Given this list of marker genes ZNF280D, ZFHX2, PKP4, NAA50, SKA2, DACT3-AS1, LINC01852, ALOXE3, LARP4, DNAJC10, ZBTB9, FOXP2, SNORA17A, GGA1, LRRC27, CNPPD1, TMEM106C, STX18-AS1, PPM1H, SMG7, PRDM1, MCFD2, IGSF8, GAS2L3, HMGXB4 (HMG-box containing 4), CORO7, NBEAL1, ATP2B1, FZD4, ARHGAP19, RELL2, SNRPA, ALKBH4, PSD, TRMO, MIR4757 (microRNA 4757), ZNF707, PSMG3-AS1, HSP90B1, RABGAP1L, KIF26A-DT, CHP1, LINC03060, LSM2, DNAJB4, ADD3, SNHG17, DRAM1, ENSG00000273828, IWS1, RNU6ATAC, LINC01465, LINC02851, RANBP3-DT, ZFAND2A, MAZ, RNF216, SWSAP1, ZNF131, DEPDC1B, PMS2, ANLN, POP1, CCDC32, POLR2E (NCBI Gene Id 5434), MRPL45P2, USP35, KCTD2, DDX55, KDM1A, MPDU1-AS1, SYT8, PCF11, CFL1, MAPT, ATP5F1C, RPS27L, UBE3A, GTF3C5, UPP1, GAPDHP25, OVCA2 (OVCA2 serine hydrolase domain containing), CLDN12, STX8, YARS2, PIBF1, IPO4, ZNF8-ERVK3-1, NBPF1 (NBPF member 1), LRRC51, CARS2, TMEM106B, ENSG00000232876, FANCC, CENPJ, NUDCD3 (NCBI Gene Id 23386), NUBPL-DT, CDK13, RNU5A-1, BBS4, RIDA, FRYL, BSCL2, HTT-AS, FGFR1OP2, FOXM1, C1QL4, SRP14, CSNK1D, ARL2BP, METTL1, GABARAP, SLC39A9 (NCBI Gene Id 55334), MIGA2, XPC, PCID2, FASTK, KCTD21-AS1 (KCTD21 antisense RNA 1), TMEM232, YWHAZ, EIPR1, ANKRD54, BBIP1, TRMT13, MAPK10, GTF2H5, ZNF740, PRPSAP1, TSSK6, MICAL3, TLCD1, ERH, RPS11, TAS1R1, RABGEF1, RPL34, PMS2P3, ATXN2, SETD1A, OS9 (NCBI Gene Id 10956), FAM118A, SETD5, TRIM29, TMED2, POLR1F (RNA polymerase I subunit F), EIF2S1, CTNNBL1, EGR1, TMEM243, VPS39-DT, DCAF13, TMEM128, HILPDA-AS1, UBE2I, PPP1R15B-AS1, PCBP2, ZNFX1, PHTF2, PARP3, PEF1-AS1, LINC00649, SERINC3, RNU6-2, KDM2B, MAPK6-DT, ZNF622, SNORD95, ZZEF1, NME6, ERCC5, SCARB2, H1-12P, HERC1, CCDC163, MRPL58, DLL4, ZFAS1, CENPQ, LINC02363, DDX11, ATP1A1-AS1, SPRTN, SNX13, DACT3, TRIM56, SNORD42B (NCBI Gene Id 26808), TENT4A, CENPO, PPP1R13L, ZNF451-AS1, NIF3L1, DYNC2I1, LRRC40, PTCD1, PDK4, THAP5, ZNF691, NCAPD2 (non-SMC condensin I complex subunit D2), H2BC8, GDAP1, DDX11-AS1, CPNE1, C3orf52, CDCA3, TRIM32, ARIH1, MRNIP, TBX6 (NCBI Gene Id 6911), ETFA (NCBI Gene Id 2108), CTNS, CTDSPL2, TRIM41, ZNF552, MMUT, PAN2, DPP8, CYP51A1-AS1, GORASP2, AMPD2, SF3B1, NFX1, UTP18, DHPS, INTS13, RABL6, SERP1, MIRLET7IHG, TPT1-AS1 (NCBI Gene Id 100190939, TPT1 antisense RNA 1), CHRAC1, TPT1 (tumor protein, translationally-controlled 1), NUSAP1, CDH24, ORC2, TPST1, ZNF524, SCP2, NDC1, TEDC2, PPP6C (NCBI Gene Id 96749), YBX3, WDR12, CACNA2D4, CACUL1, EIF3G, IER2, HNRNPAB, MINDY2, SLC27A5, STN1, ZFPL1, COQ8A, FBXO8, NRGN-AS1, MAP3K11, SUPT3H, RMDN1, TRIM7, HSPA8, METTL4, ZMYND8, ZNF8, NOL9, ATG16L1 (autophagy related 16 like 1), ENSG00000233461, FNIP1, ARMH4, MEGF8, CORO7-PAM16, SNORD12C, NOL3, ITFG2, UBAP2L, CD109, CAV1, POLR2K, RNU6-8, PRKAB2, SPINT1-AS1, EEF2K, CC2D2B, HNRNPA2B1, MIR4515, PIWIL4, ALDH6A1, RBL1, PPT1, CLNS1A, HOXA7, MYCBPAP, SLC12A9-AS1, MIR5087, HECTD4, CAPZA2, NTMT1, LYRM7, TRIM25, DNAJC14, HTRA2, RSRC2, POLK, ZNF839, RNY3, RSF1, ULK3, MEMO1, TOMM40, CARD19, MAEA, LACTB2, CCDC6 (coiled-coil domain containing 6), CNNM2, MRPL4, NLGN1, RPL8, SOCS4, YTHDC2, LRRC1, CLASP2, SHOC2, SUPT4H1, PTPA, LIN52, PPP2R5E, BLOC1S4, SETD9, RAPGEF6, CBX3, RNU4-1, STYXL1, PFDN2, AAGAB, RNF34, SLC35D3 (solute carrier family 35 member D3), RAB6A, TMCC3 (transmembrane and coiled-coil domain family 3), FIZ1, INO80E, EMC3-AS1, UQCR10, SNORD24, SF3B3, MSRB2, PPP1R2, RAD51, SNHG15, MRPS18B, ENAH, WDR81 (NCBI Gene Id 780925), GGPS1, ERC1, SLC17A5, SNORD48, ARL5A, RPL37, STAG3L5P-PVRIG2P-PILRB, CMTR1, LANCL2, BDH1, TRIM23, WEE2-AS1, UBP1 (upstream binding protein 1), WASHC5 (NCBI Gene Id 9897), GAPDH-DT, C2orf49, ELF1, RNF14, CBFB, ALG1, GABPB1-AS1, SH3TC2-DT, HTT, RPS2, CD27-AS1, ARMC10, KPNA3, YIPF3, SLC25A3, RNF181, MMACHC, TUFT1, UNC5B-AS1, CYP51A1, TMEM184A, LINC01730, LINC02453, RANBP3, KBTBD4, KHSRP, DRAIC, NUBPL, QPCTL, ZC3H12D, RFX3-DT, ENSG00000272195, ANKHD1-EIF4EBP3, TMEM9B-AS1 (NCBI Gene Id 493900), LZTR1, EMC4, CSNK2B, CCNI2, ALKBH2, GID8, NOP2, NIT1, MCCC1, CISTR, HMGCS1, LAMC2, AKT2, TMEM87A, NEK8, ERCC2, GATM, SNORD1C, MARK3, SLC38A1, PC, NCAPG2, SOCS7, ARF1, PPIL3, BDP1, LTBP4, CUX1, PTGES3, BRIX1, SCAND2P, MAP3K1, RPF2, CNBP, C6orf89, SPINK4, SH3TC2, KATNBL1, PHOSPHO1, NDUFC2-KCTD14, MYH9-DT, SRP54, MIOS-DT, ATP8B4, POLR3B, ABCF1, LAMA3, TGS1, IL23A (interleukin 23 subunit alpha), CFLAR-AS1, KIFC2, GMCL1, OIP5, MRPL33, DDIT4, TGDS, LIMA1, SERGEF, GTF2IRD1P1 (NCBI Gene Id 731516), GGCX, ANXA4, PHAX, USP42, DYNLL1, UVRAG, ZFAND2A-DT, KLF7, TMEM248, DOLK, UVSSA, ABCB10, PKMYT1, CERS6, COX20P2, NUDT21, SUV39H2, CFAP298, RAD51-AS1, BAZ2A, BIRC6, MTFR2, RPL39L, PSMB9, RNVU1-21, KRR1, PPT2, EXD1, SDCBP, GDPGP1, ALDH4A1, GSS, RERE-AS1, ZNF74, INSIG1, SECISBP2L, APRT, NSMCE2, MYO7A, MCM7, TMEM39A, TDRD3, LETM1, MIR584, ZNF473, SNHG12, RAP1GDS1, ZCWPW1, PSMA3-AS1, RPS15A, ACTR5, C1orf198, PDK1, NDUFAF4P1, COX7C, SYNJ1, SDHAF1, RBM33, CSAD, GTPBP2, RDH11, SLC4A1AP, XKR9, SELENOI, NDUFS3 (NCBI Gene Id 4722), EPB41L5, NR2C1, PLEKHH1, KCTD21 (NCBI Gene Id 283219), ANKS1A, PSMG3, IQCH, POLR3D, MIR4466, USP54, SCAMP2, MVB12A, VAV2, FHIP1B, ZNF398, ARHGEF26-AS1, RMRP, GART, CENPL, EFCAB15P, EXOSC9, CCDC77, ZZZ3, MSH5, IMMT, SEC22C, SEC31A, ARHGEF26, AGPAT5, AIMP2, GAPDH, PCBP1-AS1, NIPA1, YEATS4, CLHC1, IVD, EIF3L, ACTR3C, FSIP1, NOL8, TOMM22-DT, ZNF212, IFT172, LINC02086, FBXW7, TSEN2, NDC80 (NDC80 kinetochore complex component), ELP2, RTCA, UBE2L3, CEP120, FZD4-DT, PLEKHB2, EEF1AKMT3, NMRAL1, ARID4A, MIR7845, PUF60, TIMM21, CDON, FAM47E, DRG2, ATAD5, DDX49, CTDSPL2-DT, GPRASP3, CETN3, ZNF8-DT, DEPDC4, AJUBA, SEC24A, MRPS27, EML6, SPECC1, MTF2, STAG3L5P, GOT1-DT, HDLBP, PPP6R1, TFCP2, KNTC1, WASF2, CHMP7, INKA2, MUS81, NUDT19-DT, TYMP, ING1, TMED10, HCG18, MPV17L2, BMPR1A, AREG, FAM222B, TMEM161B-DT, ANKHD1-DT, SUPT7L, CRYBB2P1, TRIM27, VRK3, TXNDC11, UBR4, H2AC6, AMN1, UBE2Z, NFYC, MRFAP1L2, TBK1, LINC01182, KCTD13-DT, MYH9, TPK1, GPANK1, ATG4C, SPAG7, GTF3C2-AS2, ELOVL1, FBXO15, XPOT (exportin for tRNA), ATP5IF1, SNRPB2, HINT1, VWDE, SNORA84, ACP2, SLC39A6, TTC13, NOLC1, EED, BUD31, MPV17, RAD9A, TRA2A, ZC3HC1 (zinc finger C3HC-type containing 1), PRPF38B, TTC41P, MIRLET7BHG, IER3, SNHG32, TMEM143, ITPR1-DT, ZNF598, BZW2 (NCBI Gene Id 28969), PAWR, ZNF691-DT, GTF3C2, THTPA, TAF1B, EIF3H, SMG7-AS1, PEX1, TYW3 (tRNA-yW synthesizing protein 3 homolog), ANGPTL4, FEM1B, PEX26, PPP1R14B-AS1, CD320, SNRPD2, ATP6V1A, CCDC137, ARV1, HENMT1, WDR18, KHDRBS1, COG2, DNAJB12, CEP95, INO80B-WBP1, RACK1, TRIT1, B9D2, PPAN, ATP5PD, LMO7, TBC1D2, CUL4A, ZMAT5, CEP44, CCDC28A-AS1, SYNGAP1-AS1, PRSS3, DDX54, CYSTM1, DNASE2, NUP50-DT, PDAP1, SLC38A2-AS1, RPS9, NDUFA13, CAPN2, GPATCH11 (NCBI Gene Id 253635), ZNRF2P1, GOT1, RFX3, LSM11, MIR200C, APOL1, FAAP24, MAD2L1BP, ALG8, ASH2L, LARP1, POLG, YDJC, BRSK2, APH1A, RNF216P1, ZDHHC12-DT, ZBTB3, SPATA2, INO80B, SYNGR4, RPS6KA5, LRWD1, WDR27, CASD1, NUDT6, AFG1L (NCBI Gene Id 246269), PRRT1, CIAO2B, CES2, MAPK6, RITA1, DNAJC9-AS1, TUG1, TMEM39B, FDXR, CXXC1, RERE, ITFG2-AS1, AEN, GLUL (glutamate-ammonia ligase), ZSCAN2, MYO19, RPL31, CCNDBP1, PPP6R2, POM121, SEPSECS, NUP50, NSA2, SLC16A6, WDR38, SKIDA1, MED22, GCC2-AS1, POLR1G (NCBI Gene Id 10849), LRRC46, CACNB3 (calcium voltage-gated channel auxiliary subunit beta 3), SHARPIN, OGFOD1, XRCC6, RBL2, RPL34-DT, POLR1C, LINC00471, TEFM, LINC02983, CDK4, ENSG00000228395, CYB5D2, ZFP36L2, RBBP4, DUT, OSBPL8, UBN2, C2orf88, SPTAN1, CTH, PACRG, ZNHIT2, EXOC8, FAR2, ZWILCH, IQCG, NUFIP2, SSBP1, MKLN1, SPINT1, H2AC8, SEPSECS-AS1, ERAP1, FBXO9, ARFIP2, FOS, F2RL1, MIR4453HG, DESI1, LINC02405, STARD9, SYNJ2BP-COX16, PPP1R14B, NDUFB8, MMADHC, PTPN13, HM13, ZNF79, ADGRF3, MRPL45, DAZAP2, TRPM6, C2CD3, MIRLET7I, LYPD5, WDFY2, SMARCA2, ALDH7A1, COPS2, SH3BGRL3, HAUS5, RPL7A, CSNK1G1, ZNF646, PIGW, UTP11, HRK, H2BC4, RN7SL2, GABPB1, TMEM91, PHLDA1, DUT-AS1, DYRK3, ETS2-AS1, TMEM44, PDK4-AS1, LINC01144, SLFN5, HAUS5-DT, CD44, DYRK3-AS1, TMEM9B, NRP1, CDCA5, KDM3A, ENSA, RAET1K, ANKHD1 (ankyrin repeat and KH domain containing 1), NR1H3, NOB1, HYAL2, PHLDA1-DT, SNORA78 (NCBI Gene Id 677844), PTPN23, SEPTIN2, FZD1, C1orf220, RNF187, GANC, MLH1, UBQLN1, RTCA-AS1, RPLP1, SAP30L, NUP188, LTBP1, WASF1, RNF111, MYCL, MIR320A, COMMD4, PARPBP, HMGA2, SIDT1, AGR2, DDB2, ANKRD19P, TAPBPL, FAM83E, PPT2-EGFL8, USP38, DDX5, ATOSA, NDUFC2 (NCBI Gene Id 4718), H2AZ2, MSTO2P, RAD1, CUTA, SPATS2L (spermatogenesis associated serine rich 2 like), ZBTB8OS, TOMM7, PER1, CITED2, CRTAP, SHPK, PAXBP1-AS1, SHLD3, PSMD7-DT, ASXL2, PLBD1, APMAP, ADAT1, NPRL2, DUSP28, TRAPPC13, HFM1, SBF2-AS1, INKA2-AS1, AAMDC, MIR4727, MIR762HG, SYNGAP1, DYRK1A, MARCHF6, USP53 (NCBI Gene Id 54532), PTRHD1, MAF1, POLR1D, RETREG2, DDRGK1, SP4, NR4A3, HEXB, AJUBA-DT, SRP14-DT, ZNF860, SNRNP200, HNRNPH1, TMEM198B, PPP1R10, SLC35C2, KIF3A (NCBI Gene Id 11127), FBXL13, COA6, STK4-DT, PSMB10, RBM12, CXCL3, C10orf95-AS1, PNKP, MEAK7, MIR200CHG, NRBF2, CRYZ, MTR, UBE2V1, CFAP52, POLG-DT (NCBI Gene Id 119545629), GAR1-DT, DMAC2, LRRC61, MCOLN1, SLC12A9, CDC42SE1, PKM, TP53I13, GCHFR, PTPN23-DT, CLIC4, VEGFA, RCOR3, MIR22HG (MIR22 host gene), CHTOP, CFAP298-TCP10L, CABYR, WBP4, REXO2, CILK1, SNHG16, CLIC1, ZWINT, FLAD1, PLCXD2, LINC03014, ZDHHC12, ACY1, WDHD1, ELL3, OSBPL10, MICB, NAIF1, USP3, ZNF668, ARHGAP19-SLIT1, MOSPD3, RBM33-DT, IER3IP1, ABCB8, EMC3, BRAP, SERAC1, COG4, CDK13-DT, PLEC, DUSP6, IFRD1, TSNAX, CA11, MAP3K5, TMEM267, ANAPC5, TTPAL, DCP1B, NUP37, CCNL1, RAD52, HILPDA, ATP8B1, SLC25A39, AP3B2, MIR3651, SNORA16A, GSTCD, MATCAP2, MRNIP-DT, SMARCAL1, GFER, TRNAU1AP, ELP3, UGGT1, FIGNL1, ACAD10, AHSA2P (NCBI Gene Id 130872), ZNF121, IL5, ZNF451 (NCBI Gene Id 80822), ING4, RPL24, INTS12, EFHC1, MRPS7, TCF12 (NCBI Gene Id 6938), C6orf120, ZNF692, TMEM170A, TAF11, KIF26A, PIAS4, RN7SKP134, PRR11, VPS39, HDAC3, MYO9A, NTAQ1 (NCBI Gene Id 55093), PAQR4, ETFBKMT, TAFA2, CEP70, MDH2, TOMM22, RPL23A, TRIM39, SCYL2, TMEM202-AS1, LAD1, STARD3NL, UBQLN1-AS1 (NCBI Gene Id 105376114), RAD50, ENSG00000260136, TMEM177, NRAV, ATP5F1D, RNU5A-8P, ZNF180, ATP6V1D, TPX2, PTPRO, PUS7L, CWC25, SMKR1, DNAJB9, TRAPPC3, RRP9 (NCBI Gene Id 9136), TAF15, RNASEH2A, CIB2, MAP3K14-AS1, S100A6, CA5BP1, PCNX3, NFYC-AS1, ATAD3A, BBS9, MRPL51, CTDNEP1, C6orf62, H2AZ2-DT, UBR5, FRMD3, ASB3, SLC25A1, RBM48, CCDC107, CYB561D2, PEF1, GGA3, PNKD, RASGRF2, CDKN1B (NCBI Gene Id 1027), PRR15-DT, SDF2L1, SCN5A, VILL, SLC38A2, SORBS1, CORO1C, ETF1, LINC02482, CACTIN (cactin, spliceosome C complex subunit), MARCHF7, SERPINB5, ZFAND2B, TSNAX-DISC1, ARHGAP32, RGL2, MBTD1, LINC00963, KCTD13, ATRN, CARF, RABGAP1L-DT, CPSF4, CNOT8, CSTF3-DT, SMARCA4, SFMBT1, ALDH1A3-AS1, POC5, PSMB7, STK4, RAD23B, SASS6, GNL3, RPS27A, EPM2AIP1, HBS1L, LUC7L2, TIMM10B, PRKN, DCP2, SH2D6 (SH2 domain containing 6), THRAP3, TIPIN, CCDC28A, GPRC5A, ZNF410, LINC02441, PPME1, CEP89, ZSWIM9, FAM111A-DT, AUP1, ATAD2, KDM4C, DPF2, ADAMTS7P4, ANP32A, MRPS10, IMP3, LRP10 (LDL receptor related protein 10), LOH12CR2, USPL1, SNHG9, FAM168A, TAF6L, UBE4A, RNF38, PPAN-P2RY11, PIGK, ALG3, LINC00992, EGLN2, TMEM259, HMOX2, MEF2C, SRP54-AS1, ATP10B, RNU4-2, NAMPT, SH3RF2, CRAT, GAR1, SGPP1, NAA16, SERINC5, MT1E, BMAL2, PBRM1, COX19, ACTMAP, ANKMY2, SENP8, SELENOK, PGRMC2, CLCN3, CCT6B, LIG1, TMEM115, LSR, USP15, C1orf43, WDR55, CDC40, STX18, TNPO2, AP4M1, LMO7-AS1, TSPAN12 (NCBI Gene Id 23554), here is a description of the gene set: studied in species Homo sapiens from publication Yevshin I, Sharipov R, Kolmykov S, Kondrakhin Y, Kolpakov F (PMID 30445619) Human Gene Set: HOXC6_TARGET_GENES Genes containing one or more binding sites for (HOXC6) in their promoter regions (TSS -1000,+100 bp) as identified by GTRD version 20.06 ChIP-seq harmonization.